Given this list of marker genes Psap, Ar, Ube3a, Cyp19a1, Pten, Prlr, Plag1, Esr1, Shh, Sox9, Rln1, Fgfr2, Psapl1, Igf1, here is a description of the gene set: Mouse Gene Set: GOBP_PROSTATE_GLAND_GROWTH The increase in size or mass of the prostate gland where the increase in size or mass has the specific outcome of the progression of the gland, from its formation to its mature state. species: Mus musculus